Given this list of marker genes UBA52, MYD88, IRF7, UBE2V1, RPS27A, IRAK1, TLR9, UBE2N, UBC, TLR7, IRAK4, UBB, TRAF6, here is a description of the gene set: species: Homo sapiens Human Gene Set: REACTOME_TRAF6_MEDIATED_IRF7_ACTIVATION_IN_TLR7_8_OR_9_SIGNALING TRAF6 mediated IRF7 activation in TLR7/8 or 9 signaling